Given this list of marker genes PIGA, FOXP1, CP, TRNT1, SKIC2, TMPRSS6, COL7A1, CARD9, here is a description of the gene set: Human Gene Set: HP_DECREASED_CIRCULATING_IRON_CONCENTRATION The concentration of iron in the blood circulation is below the lower limit of normal. studied in species Homo sapiens Decreased circulating iron concentration